The following is a description of a gene set: studied in species Mus musculus Mouse Gene Set: GOBP_REGULATION_OF_SPERM_CAPACITATION Any process that modulates the frequency, rate or extent of sperm capacitation., and this is the list of marker genes: Tmprss12, Adam7, Tcp11x2 (NCBI Gene Id 97587), Tcp11, Spinkl (NCBI Gene Id 77424)